Given this list of marker genes BLOC1S6, DEFB1, SNAPIN, BLOC1S5, MIR31, AP3B1, PPFIA3, SYT4, DEFB106A, SLC30A3, DEFB106B, here is a description of the gene set: species: Homo sapiens Human Gene Set: GOCC_MICROVESICLE An extracellular vesicle released from the plasma membrane and ranging in size from about 100 nm to 1000 nm.